The following is a description of a gene set: species: Homo sapiens Genes down-regulated in comparison of unstimulated peripheral blood mononuclear cells (PBMC) cultured for 0 h versus PBMC cultured for 3 h with YF17D vaccine. Human Gene Set: GSE13484_UNSTIM_VS_3H_YF17D_VACCINE_STIM_PBMC_DN from publication Querec TD, Akondy RS, Lee EK, Cao W, Nakaya HI, Teuwen D, Pirani A, Gernert K, Deng J, Marzolf B, Kennedy K, Wu H, Bennouna S, Oluoch H, Miller J, Vencio RZ, Mulligan M, Aderem A, Ahmed R, Pulendran B (PMID 19029902) The immune responses generated by YF-17D by profiling genes in PBMCs from 2 donors cultured with YF-17D vaccine were accessed after 3 and 12 hours., and this is the list of marker genes: INPP5A, ARPP21, DSCAM, TM4SF4, RAPGEF2, MN1, IRF4, STAP1, MARCHF5, EHD1, JMJD6, ADAM9, GOLT1B, SLC38A2, ZFYVE16, EIF1B, INTS14, CYTIP, GADD45B, CD164, AK4, SGMS1, NRIP1, NOP10, SFXN1, PLSCR4, NAPG, TPM4, BST2, SLC5A6, CXCR3, CENPC, PCDHA3, MAGT1, PHF11, MYH10, FAS, BBIP1, IRF9, APOL1, PRC1, NUP58, DKK3, HAUS3, MITF, OAS1 (NCBI Gene Id 4938), DENND5A, S100A5, PLK3, RPL36AL, RBPMS, CORO2A, AZIN1, IFITM2, FGA, SLC26A2, PDE4DIP, CREB3, PEF1, MSC, VCPIP1, SGPL1, MYL12B, MIS12, GRK5, SNRPB, MYO6, GPRC5A, JARID2, EPS8L2, PPP2CB, LAMTOR3, MT1G, OTUD7B, PPP1CB, GGA2, OAT, PIM2, ADAMDEC1, EIF2AK2, PSMA2, TPST1, DEAF1 (NCBI Gene Id 105376508), LAMB3, MMP9, CDC27, FPR3, BCL3, ARHGDIG, MICALL2 (NCBI Gene Id 79778), ZSCAN32, LMNB1, NDST2, TMED5 (NCBI Gene Id 50999), PROCR, COQ10B, DNAJB4, MAGOH, CDC42EP2, SIDT1, ATP10A (ATPase phospholipid transporting 10A (putative)), PLAU, SLC22A4, ZC3H12A, RFTN1, PLEC, NAA50, FICD, NXT2, ACTR1A, IRGQ, KCNN1 (NCBI Gene Id 3780), UBE2L6, MXD1, P2RY4, IDO1, NAMPT, KRT19P2, SERPINB8, CASP3, RAD21, CXCL8, KCNK15-AS1, SNIP1, THBS1, DSE, PGK1, VPS37B, MMADHC, VRK2, ELOC, PITPNB, KYNU, DOCK4, HBS1L, TNFRSF12A, LAMP2, PLEKHO2, ETV6, ST8SIA4, SPATA6L, BTF3P12, FYN (NCBI Gene Id 2534), NFKBIE, ST8SIA2, ZFP30, AMPD3, MAN1C1, HIVEP3, GALNT14 (polypeptide N-acetylgalactosaminyltransferase 14), MMP1, SHFL, DUOX1, ASPH, ELK4, ABLIM1, GTF2I, MT2A, CASP7, ABTB2, CRADD, ZNF165, HMGCS1, FNDC3A, POLR3E, FASLG, TULP2, RHEB, BZW1, MED21, FCGR2B, NBN (NCBI Gene Id 4683), IL12RB2, ATXN7L1, SOCS5, HMGCS2, AKR1C1, MAGEC1, ZNF350, PSMA6, DNAJB9, TRIM5, ADM, IRS1, SPRING1, R3HCC1L, PRKAG2, SIM2, CYLD, TMOD3, ESPL1, RSRC2, PDPN, HRC (NCBI Gene Id 3270), EIF4E, SH2D2A, PTPN12, EBI3, SEPTIN10, MGAT2